The following is a description of a gene set: studied in species Homo sapiens Any process that stops, prevents or reduces the rate or extent of development, the biological process whose specific outcome is the progression of an organism over time from an initial condition (e.g. a zygote, or a young adult) to a later condition (e.g. a multicellular animal or an aged adult). Human Gene Set: GOBP_NEGATIVE_REGULATION_OF_DEVELOPMENTAL_PROCESS, and this is the list of marker genes: CMTM5, SIN3A, LIMD1, ACVR1B, MIR130B, METTL14, ANGPT4, RC3H2, CUL4A, SOX8, ING2 (NCBI Gene Id 3622), YBX3, EPHA2, IRX3, PPARD (NCBI Gene Id 5467), MIR182, RTN4R, AKIRIN1, FAT3, UCMA, GORASP1 (golgi reassembly stacking protein 1), TMEM178A, SIRT2, ACTL6B, SUZ12, MIR939, DACT3, NTRK3, NR5A1, MIR34C, BCL11A, LOXL2, SMARCD1, EFNB3, TTPA, BBS2, EFNA3, MESP1, NR1H3, SEMA3E, FOXC2, ABCA1, DICER1, NLGN1, MIR10A, PTH, NFIB, MAEL, PPP3CA, UBASH3B, CD36, RUNX3, APCS, LRP4, NGEF, HSPG2 (NCBI Gene Id 7796), EFNA1, RYK, GATA2, NKX6-2, ABCC8, WNT7A (Wnt family member 7A), HDAC7, SHH, TET1, ZBTB46, MIR130A, MIR29C, STAT3, PRDM16, NKX3-2 (NK3 homeobox 2), CCND1, HLA-G, ARHGEF15, PRAMEF1 (PRAME family member 1), PINK1 (NCBI Gene Id 65018), AMH, MYB, SRGN, SPRY1, PTPN11, HLX, DISP3, MIR212, KRAS, HRG, INPP5D, RSPO2, LDB1, MIR18B (NCBI Gene Id 574033), MIR379, MIR203A, MIR200B, GPER1, DNMT1, RANBP3L, SMARCC1, MIR204, ASPM, ERBB2, SOX15, MIR30E, GPR68, ZNF536, TLL2, IL17F, SEMA4A, TENT5C, RAI1, C11orf65, RNF10, IL18, ARHGAP4, FOXG1, LSM1, SOX11, KLK3, HDAC1, WNT9B, TGFB2, MIR222, LDLRAD4, NPR1, NEUROD2, ROCK2, ERFE, MIR34A, TLR4, IDH2 (isocitrate dehydrogenase (NADP(+)) 2), MIR675, SKIL, FUZ, MIR377, VEGFC, DYNLT1, ADIPOR1, CFLAR, BBS12, FEZF2, MIB1, MED1, SLIT1, KREMEN1, HOXA7, MIR18A, KCTD11, TNFRSF11B, NPHP3, LRP3, PHOX2B, LBX1, CLEC4G, RARB, CHRD, TAFA5, TPT1 (NCBI Gene Id 7178), STAB1, SFRP2, PAF1, PIAS3 (NCBI Gene Id 128075), FBN1, PLAC8, INHA, FIGNL2, MIR101-1, PDGFB, PTK2B, KIAA0319, MAD2L2, THY1, RBM15 (RNA binding motif protein 15), FSTL3, LBH, MGARP, PSEN1, CDK5, MUL1, ECM1 (NCBI Gene Id 1893), AGO1, CNTN2, EPHA7, RAPGEF3, NBR1, TNPO2, ANKRD26, IL17D, BCR, ACTB, HNRNPU, ZFP36L1, ADRB3, NFATC1, NKX2-1, BCL2, CCN3, IFNB1, JAK3, NOG, NR1D1 (NCBI Gene Id 9572), RAG2, DLX2, TEK, NFE2L2, RUNX1T1, CDKN2A, OLIG2, NFATC3, ECSCR, WWTR1, GABPA, PROX1, PRAMEF5, BCL2L1, BRD9, NR1H2, BTG2, NOTCH3, NOTCH4, ZC3H12A, LYN, CLDN18, ABCG1, SIX2, ARF6, BRMS1, ITGB3, STAT1, ID3, TRIO, BMPR1A, BMP5, MYC, SHC1, HGS, NKX3-1, RGCC (NCBI Gene Id 730127), SLC4A2, DNAJB11, ZNF750, HPN, FOXP1, CXCR3, ING1, PRDX2, RAP1GAP, N4BP2L2, MIR590 (NCBI Gene Id 693175), PRAMEF20, RUFY3, GDF15, INSIG1, USF3, PRL, PARP3 (NCBI Gene Id 25908), E2F2, MIR30C1, PRAMEF25, DCN, ARID4A, CTNNA1, MIR885, DUSP10, MAPK11, NDFIP1, STATH, MIR15B, COL4A3, NAXE, SIX3, RELA, MIR486-1, MAG, SLC12A2, TNR, NPPC, ID4, SOCS5, MIR329-1, EPN2 (epsin 2), SKIC8, GSK3B, SOX3, MIR505, GRIN3A, CCR1, FZD7, MIR20B, E2F1, RC3H1, MIR30B, SPRY3, EIF4E, FGF10, MED28, LMX1A, MAP2, SMARCA4, PRMT1, OSR1, H4C9, MIR214, NOCT, MAPT (NCBI Gene Id 8152), RB1, ZFP36L2, CD160, CDC73, WNT10B, SEMA4F, TRPV4, TMEM119, PARP1, NR5A2, BMP7, WNT1, CALCA, PTBP1, PTPN2, LILRB4, IL1B, TBX5, CLEC12A, ANGPTL7, RBBP4, MIR181B1, ARID4B, BRINP1, NMRK2, PF4, MIR302B, HSPA9, MIR320A, FOXE3, B2M, FBXW7, PAEP, ASPN, ZHX2, VASN, APPL2, COL4A2, KRIT1, SOCS1, ISM1, PGLYRP1, NRP1, MIR29A, MIR208A, FERMT1, STK4, WNT4, CTDP1, BCL6, CFL1, CX3CR1, BGLAP, EIF4ENIF1, PAK1, TAOK3, PRAMEF14, LIN28A, TRIB3, HMG20A, TGFB1, FUOM, CEBPA, NELFB, SYNGAP1, ZNF706, CR1, ASXL1, MIR221, HIF1A, H4C3, MYOCD, SMAD4 (SMAD family member 4), MEIS1, ROBO2, IGF2, PIK3CB, GDF11, STK11, TNF, PRAME, USH2A, TBX3, CAV3, PRAMEF15, PRAMEF33, MIR548D1, HDAC4, FOXP3, H4C11, KIT, YJEFN3, NFATC4, TSPO, GSK3A, DRAXIN (dorsal inhibitory axon guidance protein), DAB1, FBXO11, KANK1, HEY1, PRICKLE1, ITGB1, FGFR3, GDI1, NR2E1, ELAPOR2, MIR20A, SORL1 (sortilin related receptor 1), LDLR, RGMA, EZH2, CLSTN3, ANKRD2, FGF9, CSRP3, DDIT3, BHLHA15 (basic helix-loop-helix family member a15), VASH1, ZFHX3, SMAD3, DDX6, AREG, CD74, TRIM62, HDAC5, PRAMEF27, BCL7B, SMARCA2, BCL7C, MIR144, TMEM215, DLX1 (distal-less homeobox 1), MIR149, CD69, RPS6KA6, NOS3, IRF1, TBX21, ZFPM1, GDF5, ROCK1, H4C6, TSC22D1, DKK4, IHH, CARTPT (NCBI Gene Id 9607), TRPC5, TUNAR, DRD3, TOB1, STK3 (serine/threonine kinase 3), SNAI1, EPHB2, MIR103A1, EPN1, RARG, HYAL3, MBNL3, LEF1, IGF1, MMP9, MIR142, SIX4, CXCL10, MEN1 (menin 1), SAV1, ID2, H4C13, PIK3R1, RAPGEF2, TLR3, MIR199A1, MIR494, HOXA5, JDP2, RNF6, WWC1, EIF2AK4, CTDSP1, GREM1, SRGAP2C, FOXJ2, MIR137, MIR372, ADAMTS7, TWIST1, ISL2, SFRP1, GPR55, REG3G (NCBI Gene Id 130120), S1PR3, YWHAH, SEMA4D, PBX1, BRMS1L, HNF1B, NKX2-5, PLXNA3, ESRRB, TBX6, SOSTDC1 (sclerostin domain containing 1), VGLL4, HOXB8, CETP, DTNBP1, MIR21, DPF2, EPHB1, ADAMTS1, ISL1, SHOC2, ACTL6A, CALR, ADAMTS9, SEMA3F, MIR640, SOD1, TLX2 (NCBI Gene Id 51407), EAF2, DCC, IFRD1, TBX2, MIR199B, CST3, MIR92A1, H4C2, TRPC6, ADRB2 (NCBI Gene Id 154), HUWE1, HEY2, PGLYRP2, CDKN1A, TBX1, ADGRB1, MIR503, H4C4, PGLYRP3, QKI, TOMM70, RGS2, SOX2, H4C15, MARK1, DIP2B (NCBI Gene Id 57609), ENPP1, ITPKB, CTNND1, WNT9A, MYCN, HOPX, FYN, PRAMEF7, ALOX5, PRAMEF12, SLC6A4, ELF5 (E74 like ETS transcription factor 5), NGFR, CRP, THBS4, APOH, SMAD2, ATG16L1, GPR171, CNTN4, CDH3, FGF3, FLCN, MIR873, PCID2, NFATC2, PKP2, ULK1, SARS1, IL13 (NCBI Gene Id 96500), IL4 (interleukin 4), MMP11, GHRL, WWC2, STAT5A, KCNK2, WDR77, TMEM176B, ABCA5, GLI3, MIR185, CDK5RAP2 (NCBI Gene Id 55755), SAP30 (NCBI Gene Id 8819), SOX4 (SRY-box transcription factor 4), MIR98, ZBTB7B, PTHLH, IPO7, PAX8, OMA1, MIR495, ZFP36, RCAN1, YBX1, MIR515-1, SPRY2, DKK1, CDKN1B, NODAL, OGT, MIR145, WT1, CLDN5, CTSK, MIR106B, PRAMEF17, PRAMEF8, WWC3, AXIN2, TMSB4X, STARD13, REST, MEIS2, DSG2, H4C1, PLPP7, PRAMEF9, MIR17HG, SPSB3, TRIM11, FBLN5, ID1, MCF2, PLK2, MIR138-1, RTCA, AHSG, TLCD3B, LEO1 (NCBI Gene Id 123169), TP73, FASLG, NKX6-3, PRAMEF18, GATA3, TSKU, MIR193A, ZBTB16, ATP2B4, TCTA, CEACAM1, MDK, BCOR, SMAD1, CHAD, MIR106A, FOXA2, CCR2 (NCBI Gene Id 90262), MIR26A1, IL6, RBPJ, WNT3A, PRAMEF6, MIR34B, PRAMEF22, TRIM72, DTX1, HMGA2, FOXO1, TRPM4, CDK6, GPR137B (G protein-coupled receptor 137B), FXN, GDF3, SPINK5, CERS2, TNFSF4 (TNF superfamily member 4), PPARG, DAB2IP, NEPRO, LHX2, SKI, WNT11, VAT1, TCF23 (NCBI Gene Id 150921), GAS6, CDH1, PRAMEF2, HOXA2, PRAMEF19, FCGR2B, HDAC3, CEACAM5, TFRC, STC2, NKX2-2, LGMN, HHEX (hematopoietically expressed homeobox), MIR27A, FOXO4, ANP32B, SMAD6, PTPN6 (NCBI Gene Id 5777), USP19, MAFB, CDK12, LILRB3, CAV1, WEE2, SOD2, SAP130 (Sin3A associated protein 130), MSX1, BMPR2, PRKN, GTF2I, FOXO3, DIXDC1, SPRED2, CNMD, BICRA, PRTG, THBS1, RPL3L, ASCL2, DAAM2, TMEM98, MIR15A, MIR93, RBPMS2, MIR202, DLL3, ITGAV, REG3A, OPTC, GPR4, PTCH1, RARA, ALPK2, TGFBR1, TLX3, MIR125A, RIOX1, FOXA1, ANGPT2, NRARP, CBLN1, SUFU, VEGFA, EFEMP1, ADGRV1, TNFAIP6, EGFR, ZBED6, CITED1, FOXC1, SEMA3G, KLF13, SPART, MIR107, TRIM46, TCF15, G6PD, NF1, CRIM1, FBXO7, TMEM182, COL5A2, NOTCH1, SYT4, MIR100, IFNG, TNFSF18, COL5A1, SDHAF2, PRAMEF11, F2, PPP2CA, SPRED1, LOXL3, PML, PPARA, RBBP7, MYOZ1, BDNF, TMEM53, GPR137, MIR140, LAG3, MIR448, AMOT, NF2, INHBA, VAX1, PTGR3, TGFB1I1, ULK2, FGF13, SNAI2, IQCB1, DLL1, ZFPM2, NTN1, TWSG1, MIR16-1, SIRT1, MIR424 (NCBI Gene Id 494336), ATF2, SFMBT1, RBP4 (retinol binding protein 4), CTR9, GGCX, BMP4, STAT5B, S100B (S100 calcium binding protein B), MIXL1 (Mix paired-like homeobox), MIR181C, MSX2, AXIN1, LTBP3, SMAD7, CHADL, PRDM6, MIR361, TMEM176A, H4C8, SPI1, SPDEF, PRAMEF10, PRAMEF4, CCL3, ZC3H8, MIR29B1, IL4R, PDE3B, FGF8, IFNA2, INHBE, SEMA6C, FRZB, BMAL1, APOE, LAPTM5 (NCBI Gene Id 7805), SEMA6A, TRIB2, CDKL3, NEO1, TMEM64, OFD1, MECP2, SOCS2, MIR17, FGF23, BNIP3 (NCBI Gene Id 664), IFNL1, PTPN13, ANXA1, SEMA5A, SINHCAF, UBE2B, VSX2, PRMT5, TMEM131L, LRRC17, HOOK3, H4C14, BICRAL, CCL11, MIR302A, BMP2, ZNF675, SPP1, BAMBI, H4C12, SYNJ2BP, C1QL4 (complement C1q like 4), CARM1, PRAMEF26, ADAMTS12, EXTL3, WNT3, TP53, NPR2, TRIB1, MIR9-1, C1QC, GNAS, LRP5, MIR128-1, SLC7A10, BMP8B, SOX10, YY1, SPRED3, MSTN, TWIST2, TIE1, TREM2, MIR146A, SS18, MIR217, XBP1, EMILIN1, EREG, CGA, ATOH1, LTF, SUDS3, CNTF, HOXA9, PITX3, ASCL1, SORT1, THBS2, MIR19A, RFLNB, PTPRS, LEP, MIR205, FSTL4, DDB1, TEX11, NKX6-1, TNMD, ZNF354C, PI16, NPPB, WNT5A, KLF4, PHF14, ACVRL1, MIR518B, PRAMEF13, CER1, CBFB, PDCD4, SERPINE1, KLF2, SPAG9, NFKBIA, KLF7, MIR573, ZEB1, PTN, PCM1, HAND2, EDNRB, PTPRM, PDCD1, MIR19B1, YTHDF2, GATA1, RUNX1, RORA, H4C16, MIR375, IAPP, DPYSL5, GADD45A (growth arrest and DNA damage inducible alpha), FGL2, HMGB1, PAX6, TRAK2 (trafficking kinesin protein 2), RTN4RL1, YPEL4, BCL7A, MT3, BHLHE41, SHB, TP63, MAPK1, CCN4, ADGRB3, JAG1, RGS4, LILRB1, KAT8, RORB, JARID2, MIR24-1, EPHA4, CTNNB1, MIR483, GDF2, RTN4, TACSTD2, SYCP2, PAX2, IL17RD, LGALS1, TOB2, EID2B, ZNF296, MIR27B, SPARC, PTEN (phosphatase and tensin homolog), CCN6, SRSF6, ADGRB2, CDK13, INPP5F, MINAR1, LRIG2, ADCK1, MIR1298, SRA1, TP53INP1, LUC7L, IL2, OSTN, RFLNA, MIR125B1, TLR2, MIR143, MIR25, ARPIN (actin related protein 2/3 complex inhibitor), PGK1, TRIM6, GPR37L1, H4C5, YAP1, SEMA6D, ADIPOQ, GPS2, SAP30L, CREB3L1, FRS2, CCDC85B, ADRB1, FOXJ1, HES5 (hes family bHLH transcription factor 5), HDAC6, FERMT2, SMO, MIR492, POU4F2, SOX9, SULF1, HDAC2, MIR487B, OVOL2, IGFBP5, KIFAP3, CIB1, CTLA4, MIR1-1, SERPINF1, HES1, HMGB3, FST, SOX6